Given this list of marker genes Rfc3, Cops2, Polr2f, Pold1, Cops6, Cops8, Ubc, Ercc4, Polr2e, Cops7b, Rfc1, Mnat1, Rfc5, Lig3, Rps27a, Rpa3, Cops7a, Gtf2h4, Rbx1, Uba52, Polr2g, Polr2i, Polk, Pcna (proliferating cell nuclear antigen), Aqr, Gtf2h2, Ercc3, Ercc2, Polr2a, Pold3, Pold2, Gtf2h5 (general transcription factor IIH, polypeptide 5), Ccnh (NCBI Gene Id 66671), Gtf2h1, Cul4a, Polr2c, Cops5, Isy1, Zfp830, Rfc2, Polr2d, Polr2k, Uvssa, Cdk7, Pole, Xpa, Gtf2h3, Ercc5, Tcea1, Gps1, Lig1, Ddb1, Pole3, Polr2h, Cul4b, Polr2l, Ercc1, Xab2, Uba52rt, Xrcc1, Rpa1, Cops4, Pole2, Rfc4, Cops3, Rpa2, Ercc6, Ercc8, Ubb, Prpf19, Polr2b (polymerase (RNA) II (DNA directed) polypeptide B), Usp7, Pold4, Pole4, here is a description of the gene set: Mouse Gene Set: REACTOME_TRANSCRIPTION_COUPLED_NUCLEOTIDE_EXCISION_REPAIR_TC_NER Transcription-Coupled Nucleotide Excision Repair (TC-NER) studied in species Mus musculus